The following is a description of a gene set: Human Gene Set: ZAIDI_OSTEOBLAST_TRANSCRIPTION_FACTORS The use of genetically manipulated mouse models, gene and protein discovery and the cataloguing of genetic mutations have each allowed us to obtain new insights into skeletal morphogenesis and remodeling. These techniques have made it possible to identify molecules that are obligatory for specific cellular functions, and to exploit these molecules for therapeutic purposes. New insights into the pathophysiology of diseases have also enabled us to understand molecular defects in a way that was not possible a decade ago. This review summarizes our current understanding of the carefully orchestrated cross-talk between cells of the bone marrow and between bone cells and the brain through which bone is constantly remodeled during adult life. It also highlights molecular aberrations that cause bone cells to become dysfunctional, as well as therapeutic options and opportunities to counteract skeletal loss. from publication Zaidi M (PMID 17618270) An assortment of osteoblast transcriptional regulators. species: Mus musculus, and this is the list of marker genes: FOSL2, MSX2 (msh homeobox 2), FOS, JUND, JUN, DLX5, MSX1, SP7, ATF4, CTNNB1, TXLNG, DLX3, RUNX2, NFATC1